The following is a description of a gene set: studied in species Homo sapiens Human Gene Set: GOBP_GANGLIOSIDE_CATABOLIC_PROCESS The chemical reactions and pathways resulting in the breakdown of ganglioside, a ceramide oligosaccharide carrying, in addition to other sugar residues, one or more sialic residues., and this is the list of marker genes: NEU3, NEU4, NEU2, GM2A, HEXB, HEXA, GLB1, NEU1